Given this list of marker genes PIK3R2, CDC14B, IL24, ERMN, DCUN1D3, EIF3C, ESCO1 (NCBI Gene Id 114799), RCAN3, CYB561, MAP6, ACRBP, GOLGA1, NFKB1, ZNF608, RCOR3, TAFA3, DYNLT5, PPIP5K1, SGK3, TTC39C, TRIM28, STRADA (STE20 related adaptor alpha), REXO5, IL2RB, ST3GAL2, LDAF1, XPOT, ZC3H12D, STN1, MSL1, MOV10, VPS26A, HEMK1, PTPN1, PYGM, DGAT2, MTHFD2, NT5E, S100A13, IL2RA (NCBI Gene Id 3559), PPM1H, RASGRP2, FAM171B, CISH, PGBD1, ACO2, TRAF6, PTGER2, CACNA1S, DENND5A, MPZL2, TBCE (tubulin folding cofactor E), GAB2, FAM174A, ENPP1, PFN2, PTPRK, MGAT4A, LRCH3, MAN1A1, TEC, LRRC75A, CHCHD10, TNFRSF13B, SLC35D3, TMEM158, GCC1, EZH2, MAPK14, AXIN1, BAIAP2L1, LYRM1, KIF3B, SKIL, SHISA2, PRR5L, CYP4V2, MBD2, CORO2A (coronin 2A), RABGGTA, GALC, NCOA1, EPRS1, CKAP4, SNAP23, FAAP100, SRPK1, YAF2 (NCBI Gene Id 10138), CHD9, ARPC5L (NCBI Gene Id 81873), CST7 (cystatin F), KSR1, PRKCH, LRP12, G0S2, PRNP, XBP1, BICDL1, CD44, DPP4, PRIM2, TINF2, ADAMTS6, LYST, KLF7, DNAI4, FASLG, ALCAM, CHTOP, ST3GAL4, FCMR, WBP4, ABCG2, EXOC7, DNAJC21, CD2AP, ACOT2, ZNRF1, PDE8A, SOCS2, RASA1, BST1, STK10, RASGRF2, TENT5A, S100A1, TDRD7, RAP1GDS1, PRDX4, NAGK, JDP2, PIP4K2A, OSR1, C3orf18, FNDC3B, HROB, PCYT1A, TES, ZBTB12, DTX1, THEMIS (NCBI Gene Id 387357), UVRAG, ASXL1, AARS1, PEX1, FBLN2, RYBP, ZNF777, PPP2R3A (protein phosphatase 2 regulatory subunit B''alpha), SSH1, SMARCE1, DIP2C (NCBI Gene Id 22982), PIK3CD, SLAIN1, CHP1 (NCBI Gene Id 11261), CAMK4, RBM17, GNAZ, MMP11, ZNF639, ENO2, TLE6, SCAMP1 (NCBI Gene Id 9522), TLE1, UPF3A, SLC17A9, SAV1, IARS1, ZNF703, BATF3, ATF3, LTA (lymphotoxin alpha), CCDC137, CRIM1, KLRK1, SMAD2, TMCO3, ZNF623, ZNF250, PTPRA, INSL5, KLRC1, KIT, PLXNC1, C9orf72, GRHL3, PLA2G12A, MIER1, PAXBP1, PROCR, MAPKAPK2 (NCBI Gene Id 9261), GSTT1, GPR18, NLRC5, TG, CD300LF (NCBI Gene Id 146722), FAM133B, GTF2IRD2, IGF2R, TANC2, here is a description of the gene set: Human Gene Set: GSE7831_UNSTIM_VS_INFLUENZA_STIM_PDC_1H_DN CpG 1826 binds to Toll-like receptor (TLR)9, whereas influenza virus PR8 activates pDC via TLR7. Differential stimulation of pDCs is expected to result in unique activation mechanism(s) leading to a different phenotypically and functionally matured pDC We used microarrays to detail the global programme of gene expression underlying the maturation process of pDC activated with CpG 1826 and influenza virus PR8. We identified a distinct expression profile of upregulated immunomediators. Genes down-regulated in plasmacytoid dendritic cells (1h): untreated versus influenza virus infection. from publication Iparraguirre A, Tobias JW, Hensley SE, Masek KS, Cavanagh LL, Rendl M, Hunter CA, Ertl HC, von Andrian UH, Weninger W (PMID 18029397) species: Homo sapiens